The following is a description of a gene set: Any process that stops, prevents, or reduces the frequency, rate, or extent of leukocyte mediated immunity. Mouse Gene Set: GOBP_NEGATIVE_REGULATION_OF_LEUKOCYTE_MEDIATED_IMMUNITY studied in species Mus musculus, and this is the list of marker genes: Ifnb1, Klrb1b, Nectin2, Nckap1l, Gfer, Serpinb9e, Serpinb9g, Cx3cr1 (NCBI Gene Id 13051), Hmox1, Clec4g, Sh2d1b2, Il7r, Klrd1, Bcl6, Ccr2, Slamf1, Il13ra2, Cd46, Ceacam1, Tgfb1, Grb2, Nectin4, Inpp5d, Arg1, Muc4, Rabgef1, Nod2, Serpinb9f, H2-M3, Tbx21 (NCBI Gene Id 57765), Lilrb4b, Pdcd1, Foxj1, Arrb2, Cd80, Lgals9, Klre1, Spi1, Igf2, Il20rb, Clec2d, Ahr, Serpinb9d, Tap2, Parp3, Fcgr2b, Havcr2, Spn, Serpinb9b, Mill1, H2-T23, Serpinb9c, Cd96, Smad7, Hfe, Bst2, Ufl1, Vsir (NCBI Gene Id 74048), Jak3, Susd4, Abr, Ptpn6, Lilrb4a, Tap1, Ppp3cb, BC037156, Serpinb9h, Sh2d1b1 (SH2 domain containing 1B1), Cd274, Cr1l, Crk, Foxf1, C4bp, Ptprc, Bcr, Cd300a, Cr2, Ndfip1, Clec12b, Dusp22, Cd84, Il4i1, Zp3r, Serpinb9, Foxp3